Given this list of marker genes GIGYF2, SLITRK6, BCR, GRIN2C, GCH1, NBN, WASHC4, GBA1, VPS54, REST, TNF, KCNJ8, PVALEF, NPAS1, REM1, AGTPBP1, SELENON, LONRF2, STAC, SLURP1 (secreted LY6/PLAUR domain containing 1), GLRA1, NRXN1, ITPR1, FKRP, NEUROG1, SHANK3, ANKFN1, SPART, ZMPSTE24, TNNI2, UBA5, SPG21, STRIT1 (NCBI Gene Id 100508770), CCDC78, TPP1, ADCY5, TNNC1, HMX3, CAV3, MFSD8, SYNM, HIPK2, STRA6, GRIN2A, TIFAB, HOMER1, GBX1, JPH4, VPS35, HOXA1, STAC3, CSMD1, ATP2A1, BLOC1S4, DRD3, ACTN3 (NCBI Gene Id 89), CHUK, CWH43, TNNI1, DDIT3, GPR88, MECP2, CNTNAP2, SPTBN4, MYH7, SLC6A3, CHRND (cholinergic receptor nicotinic delta subunit), MYH14, PRKD1, USH1C, HSP90AA1, HOXD10, TNNI3, TTN, TUBA1A, NR4A3, AARS1, ASCL1, TNR, PNKD, PRRT2, TCAP, ELP6, GRIN2D, FXN, BORCS7, MYH10, ALDH1A3, RCSD1, PTEN, DCTN1, CNTNAP1, CLN3, HEXB, ATP8A2, KCNJ2, CLN8, RAC3, SLC1A3, VTI1A, ZNF212 (zinc finger protein 212), HOXC10, CDH23, DRD2, CHD8, MYO7A, DMPK, HERC1, FOXS1, GRID2, GAA, COMP, FGF12, EDNRA, DRD1, KBTBD13, PRKN, SHANK1, GRIN3A, PCDH15, POU4F2, MYH8, POU4F3, MYH3, EI24, UCHL1, DLG4 (NCBI Gene Id 1742), MAP1A, NPR2, ADARB1, KCNA1, NLGN2, NEFL, C12orf57, EEF2 (NCBI Gene Id 408221), POMK, COMT (NCBI Gene Id 1312), CLRN1, DVL1, PDE8B, ABL1, TNNT3, STAC2, DMD, PEX5, GSTO1, UCN, PAFAH1B1, TMEM150C, POU4F1, GSTM2, ADORA2A, GLRB, JPH3, CHRNB1, PENK, MYCBP2, CASQ1, LARGE1, SLC8A3, ROGDI, IGDCC3, SCN4A, HEXA, NKX6-2, TNNT1, DCANP1, CTNNA2, IGLON5, CAMTA1, TNNC2 (troponin C2, fast skeletal type), JSRP1, CHRNA1, ADGRD1, USH1G, TCF15, ABCC8, GM2A, FKBP1A, VPS13A, OPA3, SCN1A, GMPPA, MTOR, BACE1, here is a description of the gene set: Human Gene Set: GOBP_NEUROMUSCULAR_PROCESS species: Homo sapiens Any process pertaining to the functions of the nervous and muscular systems of an organism.